The following is a description of a gene set: species: Homo sapiens Human Gene Set: HP_ABNORMALITY_OF_VITAMIN_D_METABOLISM Abnormality of vitamin D metabolism, and this is the list of marker genes: PKHD1, GALNT2, HLA-DQB1, SLC34A1, VDR, FBLN5, SLC37A4, HLA-DQA1, IARS1 (NCBI Gene Id 3376), ALDH18A1, UROS, CYP2R1, SEMA4D, GALT, SAMD9, RPS10, TCF4, AMACR, KL, SLC34A3 (NCBI Gene Id 142680), GALNT3 (polypeptide N-acetylgalactosaminyltransferase 3), LRP5 (LDL receptor related protein 5), FGF23, FARSB, SBDS, MMP1, DZIP1L, MTTP, GATA1, SLC51B, FOCAD, CYP27B1, MST1, SLC10A1, COL7A1, DMP1, CLCN5, GPR35, CTNS, ACOX2, ELN, CYP3A4, PTH1R, EFL1, CLDN16, ENPP1, DNAJC21 (NCBI Gene Id 134218), RPL11, OCRL